Given this list of marker genes NFE2L2, DHFR, APOA4, MB, NOS3, DHFRP1, FBLN5, PRDX2, ADPRS, CYGB, PARK7, ATP7A, CCS, PRDX1, SOD2, NQO1, MPO, MT3, GCH1, SOD3, CD36, SOD1, BMP7, here is a description of the gene set: studied in species Homo sapiens Any process that results in a change in state or activity of a cell (in terms of movement, secretion, enzyme production, gene expression, etc.) as a result of an oxygen radical stimulus. An oxygen radical is any oxygen species that carries a free electron; examples include hydroxyl radicals and the superoxide anion. Human Gene Set: GOBP_CELLULAR_RESPONSE_TO_OXYGEN_RADICAL